The following is a description of a gene set: Human Gene Set: WP_SARS_CORONAVIRUS_AND_INNATE_IMMUNITY SARS coronavirus and innate immunity studied in species Homo sapiens, and this is the list of marker genes: RIGI, IFNA10, STAT2, IFNA6, IFNA7, IFNAR1, IFNA4 (NCBI Gene Id 8006), IFNA5, TICAM1, MAVS, TRAF3, IFNA17, IKBKE, IFNA16, IFIH1, IFNA21, IFNA14, JAK1, IFNB1, ACE2, IRF3, TYK2, TBK1, IFNA2, IRF9 (interferon regulatory factor 9), IFNAR2, IFNA1, IFNA13, IFNA8, STAT1, TLR3